Given this list of marker genes RUNX2, NSDHL, IFT140, SRCAP, BMPR1B, GDF5, HOXD13, MYCN, TBX5, INTU, BHLHA9, ERF, BMP2, FIG4, here is a description of the gene set: Human Gene Set: HP_ABNORMALITY_OF_THE_MIDDLE_PHALANX_OF_THE_2ND_FINGER studied in species Homo sapiens Abnormality of the middle phalanx of the 2nd finger